Given this list of marker genes MLLT3, PHIP, KLHL15, TAF9B, RPH3A, POU3F2, NHLH2, RAB14, MECOM, DNAH6, CACNA2D1, VPS35, CDV3 (CDV3 homolog), QKI, YTHDF3, SEMA4F, NDRG2, PDE4D, WNT11, KCNJ15, MFSD6, COPS4, CBX4, BLTP3A, MARCHF3, SYNPO, KIF3B, NCAM2, CORO2B, ZMAT3, MPV17, ELP5 (NCBI Gene Id 23587), ZMYM4, CALHM3, TMED3, ADCY10, CCDC144A, SLFNL1, REPS2, ADH6, ZSCAN16, BTRC, BMP4, DCAF10, LRRFIP1, CSRNP3, NGLY1, PTP4A1, GPR3, MPDZ, CPSF2, STEAP4, TTC28, MUCL3, DPH6, ZBTB44, ASPH, NUP93, CYTIP, FIGN (fidgetin, microtubule severing factor), KCNE4, USP30, C1D, CHD7, C4orf19, NICN1, TNRC6B, BBX, MS4A3, GRIK5, BNC2, RNF212, ARPP21, WIF1, ARHGEF26, PTGFRN, WDTC1, NTF3, PIP4P2, DDAH2, LARP4, TENM3, KPNA3, RND3, CPLX1, GTPBP10, CEP162, NCOR1, CBLL1, PTEN, SMOC2, SRSF1, GPR68, CDC42EP3, here is a description of the gene set: studied in species Homo sapiens Human Gene Set: MIR3974 from publication Chen Y, Wang X (PMID 31504780) Genes predicted to be targets of miRBase v22 microRNA hsa-miR-3974 in miRDB v6.0 with MirTarget v4 prediction scores > 80 (high confidence targets).